The following is a description of a gene set: Genes down-regulated by hemizygotic cre-lox knockout of RSP6 in keratinocytes. studied in species Mus musculus from publication McGowan KA, Li JZ, Park CY, Beaudry V, Tabor HK, Sabnis AJ, Zhang W, Fuchs H, de Angelis MH, Myers RM, Attardi LD, Barsh GS (PMID 18641651) Human Gene Set: MCGOWAN_RSP6_TARGETS_DN Mutations in genes encoding ribosomal proteins cause the Minute phenotype in Drosophila and mice, and Diamond-Blackfan syndrome in humans. Here we report two mouse dark skin (Dsk) loci caused by mutations in Rps19 (ribosomal protein S19) and Rps20 (ribosomal protein S20). We identify a common pathophysiologic program in which p53 stabilization stimulates Kit ligand expression, and, consequently, epidermal melanocytosis via a paracrine mechanism. Accumulation of p53 also causes reduced body size and erythrocyte count. These results provide a mechanistic explanation for the diverse collection of phenotypes that accompany reduced dosage of genes encoding ribosomal proteins, and have implications for understanding normal human variation and human disease., and this is the list of marker genes: ZNF707, SUPT4H1, FBXO38, DIDO1, ELAPOR1